The following is a description of a gene set: species: Homo sapiens Human Gene Set: HP_ABNORMAL_CEREBRAL_VENTRICLE_MORPHOLOGY Abnormal cerebral ventricle morphology Any structural abnormality of the cerebral ventricles., and this is the list of marker genes: PHC1, TCTN1, EIF2B4, ESCO2, STK36, ERCC3, SMC1A, GNB2, LRRC56, PAK3, HES7, SLITRK2, POMT2, RNASEH2A, LETM1 (NCBI Gene Id 3954), GAS1, IFT74, USP9X, XRCC2, HDAC6, ARVCF, CEP104, SAMD9, L1CAM, HELLS, RXYLT1, NUP133, TSEN54, DPH2, CC2D2A, UBE3B, ANTXR1, SHMT2, HERC1, SPAG1, CLTC, NOTCH2NLC, AMPD2, PRKAR1A, SLC4A10, CLCN7, COL3A1, MCPH1, MMP23B, TCOF1, TCIRG1, SIN3B, SLC9A6, TBC1D7, SNRPN, CASK, ITPR1, IFNG, SMARCE1, KMT2C, ERCC8, RSPH3, ZC4H2, SNX10, POMT1, RECQL4, CCDC88C, DEAF1, IFT43, DHCR7, CDC40, RAC1, P4HB (prolyl 4-hydroxylase subunit beta), NEK1, YARS1, WAC, ISCA1, BUB3, TMEM218, MOCS2, SHH, DNAAF11, CFAP300, GPC4, ACTG1, KCNN2, MAD2L2, RTTN, ERF, RAI1, CHD7, TREX1, KNL1, DHX9, DNAH5, HECW2, WDR35, PTDSS1, NRAS, SLC2A1, NDUFB11, NRCAM, GLI2, MAST1, MAX, PRKCZ, DCHS1, RNU4-2, AFF3, DSE (NCBI Gene Id 29940), CCDC40, RAF1, CARS1 (NCBI Gene Id 833), CFAP221, HIBCH, WDR62, ATP6V1A, CSPP1, SKI, PPP2R5D, ALG12, PEX19, SHPK, RAD21, CELF2, ATXN3, GNAO1, PAX6, RAB18, CEP63, KIF21A, ATXN1, CFAP74, PPP2CA, MAB21L1, ABCD1, PI4K2A, TRRAP, MINPP1, KCNJ6, ATP1A1, RAD51, ADAR, AHCY, COX16 (NCBI Gene Id 51241), FGF8, TRAIP, TSFM, DLL1, PIGB, TUBG1 (NCBI Gene Id 7283), SLC25A19, BRCA1, TAPT1, KCTD1, COG5, SEMA3E, PIEZO2 (NCBI Gene Id 63896), TRAPPC10 (trafficking protein particle complex subunit 10), WLS, VANGL1, EXTL3, TCTN3, HDAC4, SPEN, NDN, COG8, TBC1D2B, PIBF1, CLCN4, EHMT1, CFAP298, PTEN, VPS37A, DNA2, H4C9, UHRF1, AP4B1, DNAAF6, IBA57, ZIC1, SEC24C (NCBI Gene Id 9632), ERMARD, GAS2L2, FH, PPP1CB, GPR101, NGLY1, PDPN, TBCK, SOX5, SEC31A, BRF1, EVC, TP53RK, WASF1, PYCR2, DYNC2I1 (NCBI Gene Id 55112), EIF2S3, MAP2K1, WARS2, MED25, FLNA, B3GALNT2, AP1S2 (NCBI Gene Id 8905), TNFSF11, CHEK2, GRM1, AP4M1, PLXNA1, PPIL1, GPSM2, VAC14, PUS3, ZIC2, ZMIZ1, MID1, MCIDAS, SLC25A24, RBPJ, FANCE, UBE2T, TMEM67 (transmembrane protein 67), POMGNT1, ALPK3, BGN, ATP6V1B2, DNMT1, LRRC32, TMEM107 (transmembrane protein 107), NAE1 (NEDD8 activating enzyme E1 subunit 1), PIGO, DCC, MAP2K2, CHD8, GRN, PDGFRB, SIK3, FTO, RNU7-1, POGZ, IQSEC2, PGAP2, DNAAF1, SMARCC1 (NCBI Gene Id 6599), ALG13, PI4KA, NF2, PAK2, CDK10 (NCBI Gene Id 8558), FKTN, RREB1, TAOK1 (NCBI Gene Id 80214), RAB11B, GJB6, GFAP, MED12, DNAAF4, PWRN1, GTPBP2, PDHB, C12orf57, TUBB2B, COG4, DNAAF2, DNAJB13 (NCBI Gene Id 374407), DNM1, POLR1A (NCBI Gene Id 90784), RAB3GAP2, CPT2, IDUA, SNORD116-1, POMK, RNASEH2B, BLTP1, TYROBP, CYFIP2, FOXP3, NAXD, IRF4, ATP6V1E1, SF3B2, FAM111A (FAM111 trypsin like peptidase A), AFG2B, B9D1, MAPKAPK5, KNSTRN, KCNAB2, SLC31A1, SETD2, KDM4B, TNPO2, NODAL, PRDX1, FGFR3, NAA80, OCRL, CHD3, PRDM16, TRPM3, LSM11, TMCO1, WDR45B, DLG5, ZMYND10, TNFRSF11A, NEXMIF, NDE1, NKX3-2, PMM2, H1-4, DTYMK, ARL13B, YWHAE, SARS1, NAA10, CCDC22, KATNIP, HRAS, CEP57, DNAH1, KANK1, ARID2, COX6B1, CHST14, BICD2, THOC6, KIF7, PAFAH1B1, TXNDC15, SLC32A1, PEX1, ASXL2, COX7B, ZNHIT3, DIAPH1, CPLANE1, ASNS, TRAPPC14, VPS35L, PTPN23, CRPPA, FOXH1, DPF2, MRPS16, CFAP43, TRAPPC12, WDR73, ARMC9, BUB1B, GLI3, CRTAP (NCBI Gene Id 253263), ERCC5, GLB1, MAN2C1, TSEN15, PIGQ, TRIP13, GRIN1, FAT4, EP300, LMNB1, JAM2, FANCF, NANS, BRIP1, CTDP1, NEK10, HYLS1, FANCD2, SMARCD1 (NCBI Gene Id 6602), SIM1, TUBB3, HYDIN, SHOC2, ZPR1, ANKLE2, RNF125, TBX4, PALB2, TRPV6, CSGALNACT1, TRMT1 (NCBI Gene Id 55621), HIRA, PDE2A, DPM1, ADGRG1, ZNF148, FARS2, B3GALT6, TSC2, LMNB2, AHDC1, TTC12, TIMMDC1, SLC39A8, AHI1, NUP88, ANKH, SPG11 (SPG11 vesicle trafficking associated, spatacsin), KIF5A, NEU1, VPS53, COG6, MMACHC, CDKN1C, SLC17A5, MRE11 (MRE11 homolog, double strand break repair nuclease), TBX15, EVC2, PDHA1, MYT1L, RTEL1, MFN2, CDON, RPGRIP1, HBA2, CHST3, NF1, B9D2, DYRK1A, RAD51C, GLUL, ERCC2, TET3, PTCH2, B4GALT1, CDKN2A, PDGFB, DNAL1, MT-CYB, DOK7, ATP1A3, MARS2, ARSB, YY1, FANCM, CEP41, OFD1, AMER1, TGFBR2, SPRED2, ZNF462, TAF6, SATB1, TUBGCP2, SMAD2, POMGNT2, RNF113A (ring finger protein 113A), KAT8, CTSC (cathepsin C), B4GAT1, TMEM237 (NCBI Gene Id 65062), TREM2, SPIN4, ZFX, OTUD6B, FANCG, FBXO28, PEX10, MYMX, TGDS, UNC45A, FAR1, CCL2, H3-3A, SPEF2, SLC35A2, VRK1, LUZP1, KMT2D, NSUN2, ODC1, RRAS2, MYORG, NSD2, BCAP31, GBA1, ANKRD11, NUP37, ALDH6A1 (NCBI Gene Id 4329), RNF213, MPDZ, CYP26C1, EIF2B5, RPGR, GRIP1, MUSK, RNASET2, FOXRED1, GALC, RFWD3, FGFR2, CDC42BPB, ATP11A, CPLX1, TUBA1A, TOE1, AARS1, NUP107, SV2A, FANCC, DAG1, TINF2, LARGE1, SALL1, LONP1, IFT172, RSPO2, NFIB, PUF60, IFT80, ALDH7A1, OSTM1, TARS1 (threonyl-tRNA synthetase 1), NCAPG2 (non-SMC condensin II complex subunit G2), TMTC3, PUM1, ZSWIM6, GMPPB, SNIP1 (NCBI Gene Id 79753), GRIA3, RPGRIP1L, ROBO1, GET4, HNRNPU, CREBBP, EXOC2, SMOC1, GCDH, CENPF, ESAM (endothelial cell adhesion molecule), NDST1, ZIC3 (Zic family member 3), VPS33A, MTOR (mechanistic target of rapamycin kinase), DNAH11, STRADA, ARX, SETBP1, TBCD, FAM20C, MBTPS2, YME1L1, CRB2, OSGEP, RSPH9, ALK, CLP1, DPYSL5, CUL4B, ATP6AP2, LAMB1, MOCS1, ZBTB20, FIG4, ODAD2 (NCBI Gene Id 84104), FRA10AC1, ZNF423, MPDU1 (NCBI Gene Id 9526), OGDH, MKRN3, HNRNPK, PIK3CD, HK1, RSPH4A, FOXF1, MKS1, NHLRC2, GABRD, ADNP, IGF2, XRCC4, EBP, SON, CCDC174, AP4E1, HS6ST2, EIF4A2, MCM7, MFSD2A, WDR4, TMEM216, NPHP1, MAF, AKT3, COPB2, HSPG2, PRKAG2, DENND5A, DNMT3A, ATXN2, IARS2, DPH1, HSD17B4, SOX9, SOX2, COASY, TRAPPC6B, SMG9, CEP83 (NCBI Gene Id 51134), PMPCA, VANGL2, PLOD3, RASA1, ERCC4, OCLN, PCNT, CDC42, TMEM231, ZEB2, NIPBL, PEX2, BRCA2, DKC1, GOSR2, AIP, RAPSN, POLRMT, CCND2, TMEM138, TRAF7, KAT6B, NFIA, RERE, COX20, TBC1D24, CTBP1, VSX1, FRAS1, ASXL1, CEP152, WDR26, SLC13A5, MTHFS, PRNP, ACTB, DHX37, CEP135, PLCH1, FLI1, SLC29A3 (NCBI Gene Id 8072), SRPK3, TAF2, KCNQ1, CLXN, MSL3, NME8, SMC3, MTHFR, CEP290, FUZ, ZBTB24, NEDD4L, POR, NCAPD3, EBF3, TTC5, QARS1, GFM2, SLC18A3, OTUD5, GTF2H5, KPTN, KIF26A, FANCI, WASHC5, RSPH1, PARN, TAF8, EXT1, SCO2, FANCA, CCDC88A, TPRKB, LAGE3, DYNC2H1, FBP1, ARL3, PWAR1, TGIF1, UGDH, NSD1 (nuclear receptor binding SET domain protein 1), WARS1, TRNT1, PNKP, RNASEH2C, PLPBP (NCBI Gene Id 11212), SOX11, SIN3A, TMX2, PIGA, RRAGC, ODAD4, RAC3, NPHP3, ZBTB11, CRIPTO, CHD4, ZNF292, NOTCH1, SF3B4, PLAA (NCBI Gene Id 9373), ACP5, ARHGAP31, LAMA1 (laminin subunit alpha 1), PTCH1, SLC12A6, TBX1, AKT1, DHCR24, ASPM, DRC1, KIDINS220, PDE6D, KMT5B, GON7, PIGV, MAG, TUBA8, GNAQ, EOGT (EGF domain specific O-linked N-acetylglucosamine transferase), KPNA3, PORCN, EMG1, RNU12, ADAT3, SUMF1, SLC6A9, FKRP, CTNNB1, HTRA2, UBTF, TBL1XR1, JAM3, TSC1, SIX3, DONSON, KCNK4, SMARCC2, HBA1, DNAAF3, ZBTB18, CDCA7, COL4A2, ALG3, CASP2, ERCC6, STIL, HDAC8, DISP1, CSF1R, GNAS, IDS, CUX1, BRAF, COMT, PIGU, CENPE, KRAS, MYMK, IDH1, NOTCH2, DNAH9, ODAD1 (outer dynein arm docking complex subunit 1), SPTBN1, PDHX, PPFIBP1, SMARCB1, SLC25A1, KIAA0586, RAP1B, BMP4, OPHN1, CCDC39, TAF13, MAGEL2, NOTCH3, WNT3, B3GAT3, BCOR (BCL6 corepressor), BMP2, CDK5RAP2, NDUFA6, SHQ1 (SHQ1, H/ACA ribonucleoprotein assembly factor), USP7, TGFBR1, LIPT2, NIPA2, GABBR2, PYCR1, MPLKIP (NCBI Gene Id 136647), COX8A, FBXW11, MYOD1, GRIK2, IFT140, NDUFA8, PGAP3, FLVCR2, FLII, TRIM37, ROGDI, EZH2, TP53, PIK3R2, C2CD3, USP18, SEPSECS, KCNQ1OT1, WBP4, PIK3CA, FBXL4, PPP1R12A, UFD1, RPS6KA3, TBCE, CILK1, CLCN3, POLR2A, BICRA, COG1, NME5, TRIM71, COL4A1, METTL5, STAG2, D2HGDH, CEP120, TCTN2, CTCF, TCF4 (transcription factor 4), ASXL3, TUBB, INPP5E, RHOBTB2, CDK6, DNMT3B, LIPT1, WDR81, PPP1R21, TUBB2A, PGAP1, PSAP (NCBI Gene Id 83009), EXOC8, VPS51, SCN4A, ARID1B (NCBI Gene Id 645070), DCX, TRPS1, APC2, SMO, FOXJ1, PLG, SLC20A2, MTRR, GP1BB, TNNI3, DDX3X, DLL4, LMBR1, THOC2, TMEM147, HTT, MEF2C, KRT5, ZNF335, CIT, PUS7, KIFBP, PHGDH, GJB2, NIPA1, KDM1A, YRDC, FGFRL1, HERC2, KIF14, TMEM222, TSEN34, MAPRE2, OCA2, DNAI2, CASZ1, DHX30, KATNB1, MNX1, BUB1, TXN2, HNRNPH1, MTM1, FANCL, GAN, NDUFS2, SEC24D, XPR1 (NCBI Gene Id 9213), DNAAF5, STAC3, MT-ATP6, ATP6V0A2, TBXT, CTNNA2, RNU4ATAC, PCDH19, EML1, INTS11, JMJD1C, FBN1, SMARCA4, UBE4B, YIPF5, TSEN2, MAN2B1, KANSL1, SOX4, KRT14, TBK1, GUSB, DYNC2I2, SASS6, DNAI1, PSAT1, KIAA0753, INTU, DMPK, TOGARAM1, CTSF, POLR3A, HCCS, SAMHD1, BRD4, TAF1, PHACTR1, SNORD115-1, NDUFS8, EPHB4, IFIH1, SUCLA2, AARS2, KLHL15, BAP1 (NCBI Gene Id 8314), KDM6A, ALG8, IFT56, COL18A1, CBY1, NUP188, SLX4, LIG4, ARSI, DOHH, VPS13A, FGFR1, CCNO (cyclin O), ALG2, ACTA2, PPP2R1A, ARID1A, TRPV4, SH2B1, VPS11, MYCN, MDM2, PIGG, TERT, NAXE, ODAD3, SHANK3, B3GLCT, DOCK6, NADK2, NPAP1, GPC3, NFIX, RAB3GAP1, ACBD6, EOMES (NCBI Gene Id 8320), PIGN, FANCB, GTF2E2, HEPACAM, HUWE1, ZNF699, SUFU, ACD